Given this list of marker genes Mst1, Adipoq, Pkib, Pkia (protein kinase inhibitor, alpha), Sirt1, Rapgef2, Spatc1l, Htt, here is a description of the gene set: Mouse Gene Set: GOBP_REGULATION_OF_CAMP_DEPENDENT_PROTEIN_KINASE_ACTIVITY studied in species Mus musculus Any process that modulates the frequency, rate or extent of cAMP-dependent protein kinase activity.